The following is a description of a gene set: Human Gene Set: HP_CUTANEOUS_MELANOMA Cutaneous melanoma The presence of a melanoma of the skin. species: Homo sapiens, and this is the list of marker genes: COL17A1, OCA2, SOX5, COL7A1, POLH, XPC, CDKN2A, MITF, MMP1, WRN, ZEB2, STK11, BAP1, MC1R, BRAF, RAF1, ALK, ERCC3, HRAS, NRAS, CDK4, CXCR4